The following is a description of a gene set: studied in species Homo sapiens The chemical reactions and pathways resulting in the formation of precursor metabolites, substances from which energy is derived, and any process involved in the liberation of energy from these substances. Human Gene Set: GOBP_GENERATION_OF_PRECURSOR_METABOLITES_AND_ENERGY, and this is the list of marker genes: SOD2, ATG2B, IDH2, ACAT1, FECH, ATG3, NDUFS3, MTFR1L, TRAP1, INSR, NUPR1, NDUFS7, ALDOA, KL (NCBI Gene Id 9365), TYRP1, ANTKMT, HK3, MT-ND4L, PINK1, VPS54, POMC (NCBI Gene Id 5443), GAA, ADIPOQ, LEPR, COX6B1, ADHFE1, TEFM, MDH1, ATP5F1A, UCP2, UQCC3, IDH1, GPR180, MIR1271, PRKACA, MT-ND4, AACS, ENO4, SDHAF2, PRDM16, PDX1, TP53, ACO2, SLC25A33, PCDH12, PPARA, OGDHL, GPI, CBFA2T3, NDUFV3, AGL, XYLB, PPP1CA, CS, ABCC9 (NCBI Gene Id 102724274), COX7B2, ETFB, PRLH, PPP1R3E, KGD4, PPP1R2B, SLC25A51, PKLR, COX10, PKM, GRB10, IDE, EPM2AIP1, FXN, PPP1R3A, MCHR1 (melanin concentrating hormone receptor 1), PANK2, ETFA, NDUFA1, PYGB, ACSM1, PLEC, ADGRF5, COX4I2, PDIA5 (NCBI Gene Id 10954), EIF6, DLAT, WDR93, LYRM7, ENO3, NDUFS1, PFKFB2, G6PC1, STAT3, OGDH, IDH3B, SUCLG1, ALDH1L2, SLC25A14 (NCBI Gene Id 9016), CHCHD10, MT-ND2 (NCBI Gene Id 4536), VGF, PGAM2, SUCLA2, MT-CO1, UQCC2, UCHL1, PRPS2, ENO2, POR, SDHC (NCBI Gene Id 6391), CYCS, EPM2A, SURF1, ATG2A, MDH2, COX7A2P2, NDUFA10 (NADH:ubiquinone oxidoreductase subunit A10), FOXK2, MLST8, ENPP1, COX7A2, GYG1, MT-ATP6, PGAM4, MTFR2 (mitochondrial fission regulator 2), SRC, SELENOS, PFKM, ACACB, NDUFA5, COX4I1, P2RX7, GSK3A, OAS1, SDHA, COX17, NOP53, WIPI2, PRKAG1, SLC25A23, NIPSNAP2, COQ10B, ASIP, NDUFA7, MIR15B, C2orf69, MTFR1, ATP5PF, IGF2, COX7C, GFPT1, EP300, PRKAA1, PPP1R3G, NDUFS4 (NCBI Gene Id 4724), UQCRHL, SLC4A1, COX8A, SIRT3, DLD, PARK7, ACADVL, IGF1, IFNLR1, HMGCLL1, PPP1R3B, IL4, PDHB, TKT, GBE1, COX7A2L, CDK1 (cyclin dependent kinase 1), OXA1L, NDUFC1, CAVIN3, COX7B, SDHB, MTLN, NDUFS5, TRPV4, COX7A1, NDUFAF1, SNCA, PGK2, BID, COX8C, BLOC1S1, PID1, DLST, SLC4A4, PFKFB1, NDUFA2, GHITM, NDUFA11, CXXC5, PPP1R1A, UQCRFS1P1, PDHA2, NR1D1, GAPDHS, TNF (tumor necrosis factor), ATP5F1B, MYBBP1A, NDUFB5, HK2 (hexokinase 2), WDR45B, GFPT2, ADGRF1, STBD1, GALK1, PRKAG3 (protein kinase AMP-activated non-catalytic subunit gamma 3), UQCRH, DDIT4, PPP1CC, UQCRFS1, ATP5ME, MIR195, NDUFA9, FDX2, NDUFV2, SCO2, UQCRB, ENOX2, RUBCNL, DHRS2, FOXK1, TIGAR, PASK, AVPR1A, NOS2, PPP1R2P1, MT-ATP8, INS, MT-CYB, PUM2, DGUOK, STOML2, RBPJ, ADPGK, GYS2, OPN3 (NCBI Gene Id 23596), ATP5F1C, MRAP2, ADSL, TALDO1, RHOA, SLC27A5, COX6B2, UCN, NDUFA12, HMGCL, VCP, SDHAF4, PHKA2, ARL2, PDHA1, GSK3B, CYC1, UQCR11, CHCHD2, GCK, MLXIPL, INPP5K, PSEN1, NDUFA3, NCOR1, FLCN, PPP1R3C, MLDHR, PFKFB3, IER3, ABCD1, IL10RB, NDUFV1, LEP, NDUFA4, AKT1, NDUFB6, DYRK2, UQCR10, CYB561, CEBPA (NCBI Gene Id 1050), IRS1 (insulin receptor substrate 1), PFKP, HIF1A, PGD, RPE, ATPSCKMT, RB1CC1 (NCBI Gene Id 9821), CAT, COX6A1, AVP, TREX1, UQCRC2, ATP5F1D, MACROH2A1, PHKG1, ATP5PO, COX5B, ARNT, TPI1, ETFDH, MTOR, WDR45 (NCBI Gene Id 11152), UQCRQ, NDUFB1, AIFM2, SORBS1, NDUFB9, DHTKD1, PGM2, MT-ND1, NDUFA13, PRKAG2, SHMT2, IL6ST, COX5A, COQ10A, HK1, NDUFB7, GAPDH, PYGM, PPIF, ATP5MF (NCBI Gene Id 9551), ACO1, THAP11, OXCT1, SUCLG2, SHPK, EVA1A, COX6A2, H6PD, ACTN3, STK40, MFN2, ENSG00000293600, DNAJC15, IFNG, SLC25A4, PHKA1, ISCU, PGAM1, MT-CO3 (mitochondrially encoded cytochrome c oxidase III), NDUFB2, MTCO2P12, BPGM, PNPT1, HKDC1, G6PD, GIT1, ZBTB20, COL6A1, MFSD8, ATP5MG, FDX1, PPARGC1A (PPARG coactivator 1 alpha), CHCHD5 (NCBI Gene Id 84269), GABARAPL1, GBA1, NDUFS2, GCGR, MSH2, SDHD, COX6C, SIRT6, GYS1, PRXL2C, NDUFA8, PIK3CA, SLC25A13, LDHA, NDUFC2, PPP1CB, ATP7A, AKT2, GNPDA1, ATG12, NNT, MT-ND3, CSKMT, ACOX1, GNMT, PRELID1, NDUFA6, ADRB3, ZBTB7A, MDH1B, NFATC4, FBP1, NDOR1, UQCRC1, SLC2A6 (solute carrier family 2 member 6), APP (NCBI Gene Id 351), AK4, IMMP2L, NDUFAB1, CYP1A2, NDUFS8 (NADH:ubiquinone oxidoreductase core subunit S8), NDUFB4, PPP2CA, MT-CO2, COA6, GIPR, ALDOC (NCBI Gene Id 230), DERA, PPP1R2, TMEM135, HCCS, OGT, RPEL1, NDUFC2-KCTD14, PHKB, HMGB1, LIPA (NCBI Gene Id 3988), COMT, ALDH1L1, PHKG2, NDUFB8, ETFRF1, IRS2, PFKL, MT-ND5, OXCT2, HMGCS2, NDUFB3, FDXR, IDH3A, RBKS, ATP5PD, ACSS3, RPTOR, ATP5PB, UGP2, ATP5F1E, PPP1R3D, FKRP, DNAJC30, PGK1, KAT2B, ADCY10, ENO1, ATP5IF1, HDAC4, CROT, BCL2L13, GYG2, NR4A3, PYGL, COQ9, RPIA, ATP5F1EP2, KHK, THTPA, GPD1, IFNAR1, HTR2A, NDP, NDUFB10, ME3, FH, PTH, PRKAA2, MT3, TRIM63, ALDOB, PER2, MTCH2, SELENON, MIR210, ACADM, PPARD, CCNB1, NDUFB11, PPP1R3F, IDH3G, PGLS, NDUFS6 (NADH:ubiquinone oxidoreductase subunit S6), MT-ND6, JMJD8, NHLRC1, PGM1, PHLDA2, SLC25A25, CISD1, WIPI1